Given this list of marker genes DNAJC13, LRRK2, WDR45, GBA1 (NCBI Gene Id 82008), CNTN1 (NCBI Gene Id 1272), SLC18A3, NR4A2, RAPSN, CHRNG, CHRND, DNAJC6, SNCA, KARS1, CHRNA1, MAGEL2, MYOD1, FGF14, NEB, SYNJ1, EIF4G1, NDUFA13, NUP88, ERBB3, MUSK, MAPT, PODXL, DPAGT1, FLVCR2, ATP13A2, FXR1, DOK7, CP, VPS13C, TUBA1A, TMEM240, VPS35, GIGYF2, DCTN1, KIF21A, PANK2, TOR1A, here is a description of the gene set: Akinesia studied in species Homo sapiens Human Gene Set: HP_AKINESIA Inability to initiate changes in activity or movement and to perform ordinary volitional movements rapidly and easily.